Given this list of marker genes Dnase1l3, Fcgr3, Il4ra, Lypd10, Fcer1g, Pram1, Adora3, Snx4, Cxcl5, Tyrobp, Arg1, Bcr, Nppc, Fcgr1 (NCBI Gene Id 99852), Cd300a, Ddx1, Stap1, Stxbp2, Stx4a, Crhr1, F2rl1, Pld2, Dhx36, Cx3cr1, Cd84, Btk (NCBI Gene Id 215271), Ticam1, Nppa, Mavs, Cd177, Sphk2, Gata1, Abr, Il13ra2, Rabgef1, Vamp8, C3, Rac2, Foxf1, Ccr2, Itgb2l, Itgb2, Spi1, Lypd11, Adora2b, Fcer1a, Il13, Gata2, Gab2, Ighg2b, Stxbp1, Pdpk1, Il4, Ddx21, Ptafr, Hmox1, Dnase1, Fgr, Syk, Unc13d, H2-T23, Cxcl1, Fes, Pomc, Ighg1, Ms4a2, Rigi, D6Wsu163e, Lyn, Itgam, Pla2g3, here is a description of the gene set: Any process that modulates the frequency, rate, or extent of myeloid leukocyte mediated immunity. Mouse Gene Set: GOBP_REGULATION_OF_MYELOID_LEUKOCYTE_MEDIATED_IMMUNITY species: Mus musculus